Given this list of marker genes CISH, S100A10, STARD4, MGAT4B, STXBP1, DOK2, DHCR24, ACTG1, ICA1, TMTC2, FLOT1, SLC38A10, ADGRE5, TNFRSF8, CTPS2, PLEKHG3, MOCOS, RNF11, CRIP2, CYP20A1, SYNE2, NXT2, CPSF2, SCP2, ATXN1, RAPSN, MFSD6, ESRP2, EVI5, IRAK2, MPPED2, SLC37A2, ANTXR2, F13A1, BAG3, CAV2, MIR24-2, PROS1, SH2B1, FBXL5, LAT2, LAPTM4B, JAZF1, PTPN5, PPP1R3F, HCLS1, KLF10, CD320, AP3S1, ARHGAP18, SPECC1, CCND2, ARL4A, DUSP6, PLK3, FAF1, CYSLTR2, SRGAP3, DNAJC12, ZCCHC24, ACADS, PTGS1, RHOB, PNP, FUCA2, PARP16, VPS54, LONP2, FKBP5, CD44, RIPK3, CYB5R4, GPR68, NSDHL, WDR26, ANXA4, PTP4A1, GIMAP7, EZR, FOSL2, PLEK, PCBP4, MIR19A, LMNA, C2CD2, ZMPSTE24, MAMDC2, BCL2L1, ATP2B4, SELENOI, ASPH, KIF13B, IL12RB1 (NCBI Gene Id 3594), SIT1, DHRS7, ZFAND6, ARL10, RAB29, ARHGAP27, FAM114A1, SDCBP2, HEXIM1, DUSP3 (NCBI Gene Id 284066), LRRC49, SGK1, CEBPB, SPIN1, ACLY, MAPKAPK3, RAB20, ID2, GPR153, PTPN13, ARRB1, IDI1, ECH1, CTLA4, GGTA1, RALB, ZCCHC18, FAH, PTTG1IP, HMGCR, KLF11, PDCD1 (NCBI Gene Id 56179), AKAP7, ITPRIPL1, CYTH2, TEP1, GABBR1, ODC1, TMOD3, GRB2 (growth factor receptor bound protein 2), GPBAR1, CRYBG1, SNUPN, EHD1, SLC39A6, TNFRSF18, POLK, PLEKHB2, LDAF1, NIBAN1, GPR132, KHNYN, MCUB (NCBI Gene Id 55013), ADCY7, BIVM, VCL, BMAL1, CAP1, PTPRU, UNC45A, KLF12, HTR2A (5-hydroxytryptamine receptor 2A), TUBB6, CDR2, GALC, CDKL2, DNAJA1, SLC16A6, BCO2, ITGAV, ABCB10, GIMAP8, ARL5B, BICD1, TMEM64, NAAA (N-acylethanolamine acid amidase), C16orf54, CAMK2G, UBC, MCU, ULK3, TTBK2, here is a description of the gene set: Human Gene Set: GSE37301_PRO_BCELL_VS_GRANULOCYTE_MONOCYTE_PROGENITOR_DN from publication Ramirez K, Chandler KJ, Spaulding C, Zandi S, Sigvardsson M, Graves BJ, Kee BL (PMID 22608498) Expression profiling of Rag2-deficient Ets1++ and Rag2-deficient Ets1-- mature NK cells and WT bone marrow progenitors, WT T cells, and WT Pro B cells Genes down-regulated in pro-B cells versus granulocyte-monocyte progenitors. species: Homo sapiens